Given this list of marker genes Hip1r, Wasl, Dab2, Dgkd, Dnm2, here is a description of the gene set: species: Mus musculus Mouse Gene Set: GOBP_POSITIVE_REGULATION_OF_CLATHRIN_DEPENDENT_ENDOCYTOSIS Any process that activates or increases the frequency, rate or extent of clathrin-mediated endocytosis.